The following is a description of a gene set: species: Homo sapiens Human Gene Set: GOMF_INTRAMOLECULAR_OXIDOREDUCTASE_ACTIVITY_INTERCONVERTING_ALDOSES_AND_KETOSES Catalysis of an oxidation-reduction (redox) reaction in which the hydrogen donor and acceptor, which is an aldose or a ketose, are the same molecule, and no oxidized product appears., and this is the list of marker genes: HYI, TPI1, GPI, MRI1, RPIA, MPI